The following is a description of a gene set: Cytokines mediate cell-cell communication in the immune system and represent important therapeutic targets. A myriad of studies have highlighted their central role in immune function, yet we lack a global view of the cellular responses of each immune cell type to each cytokine. To address this gap, the authors created the Immune Dictionary, a compendium of single-cell transcriptomic profiles of more than 17 immune cell types in response to each of 86 cytokines (>1,400 cytokine-cell type combinations) in mouse lymph nodes in vivo. A cytokine-centric view of the dictionary revealed that most cytokines induce highly cell-type-specific responses. For example, the inflammatory cytokine interleukin-1β induces distinct gene programmes in almost every cell type. A cell-type-centric view of the dictionary identified more than 66 cytokine-driven cellular polarization states across immune cell types, including previously uncharacterized states such as an interleukin-18-induced polyfunctional natural killer cell state. Mouse Gene Set: CUI_T_CELL_CD4_IL36A_RESPONSE_UP studied in species Mus musculus from publication Cui A, Huang T, Li S, Ma A, Pérez JL, Sander C, Keskin DB, Wu CJ, Fraenkel E, Hacohen N (PMID 38057668) Genes positively differentially expressed in cell type: CD4+ T cell upon treatment with cytokine: IL-36α in mouse lymph nodes in vivo., and this is the list of marker genes: Gbp7, Snrpd1, Psma3, Psma6, Eif2s2, Oas3, Snu13, Psmc3 (proteasome (prosome, macropain) 26S subunit, ATPase 3, NCBI Gene Id 19182), Odc1, Mrpl52, Polr1h, Tnfrsf25, Psma7, Mycbp2, Psmb5, Dad1, Ndufb9, Arpp19, Hdgf, Tmbim6, Selenow, H2-T22, Snx3, Phf5a, Uba1, Psmc5, Ifi35, Lgals3bp, Tars1, Irgm2, Relb, Bst2, Krtcap2, Nampt, Pml, Denr, D8Ertd738e, Calhm6, Skap2, Pa2g4, Snrpb, Phf11b, Eif3c, Trim34a, Ptp4a2, Idnk, Mrps34, Set, Ppa1, Phf11c, Gbp4, Cycs, Bola2, Notch1, Samsn1, Cox7b, Hnrnpa2b1, Ly6a, Usp18, Psma1 (NCBI Gene Id 26440), H2-T23, Mapkapk2, Tbrg1, Pcbp1, Mvp, Trim12a, Pou2f2, Igfbp4, Satb1, Snrpa1, Rab8b, Impdh2, Magoh, Ldha, Slfn5, Usp25, Isy1, Pdap1, Ddx24, Hsp90ab1, Yars1, Tgtp1, Nme1, Polr2f, Pdcd5, Psmb8, Elob, App, Sp110, Ddx60, Nfkb2, Cd82, Atp5f1d, Lars1, Ifit3b, Atxn2l, Erh, Ndrg3, Cd53, Gbp2, Sys1, Zbp1, Herpud1, Rtp4, Ier5, Ptma, Dhx58, Psmc4, Cct3, Psmg4, Slc3a2, Ctss, Sdf4 (NCBI Gene Id 20318), Anp32b, Uqcc2, Bud31, Anxa6, Dbnl, Cltb, Phip, Tapbp, Il2rg, Cebpb, Lgals9, Samhd1, Irf8, Rbm8a, Ly6c1, Isg20, Psma2, Sar1a, Sdhaf1, Etv6, Ssbp4 (NCBI Gene Id 76900), Jund, Stip1, Il21r, Insl6, Nmi, Sting1, Iars1, Tuba1b, Dynll2, Tcf7, Plaat3 (NCBI Gene Id 98147), Pim1, Atp5mf, Anp32e, Mitd1, Sf3b5, Mthfd2, Psmb9, Ms4a4c (membrane-spanning 4-domains, subfamily A, member 4C), Sars1, Psmb4, Eif5b, Ndufb7, Rnf213 (NCBI Gene Id 672511), Gbp8, Tgtp2, Crem, Sec61g, Psma5, H2-D1, Shmt2, Cacybp, Trim56, Bzw2, Nfkb1, Ybx1, Nop56, Larp1, Sumo2, Ly6e, Arid5b, Rcc2, Ube2l3, Gbp9, Uqcrq, Cwf19l2, Trp53, Trafd1, Parp14, Psat1, Chmp4b (charged multivesicular body protein 4B), Eif1ax, Chchd1, Aldh18a1, Hspa8, Samd9l, Slfn1 (NCBI Gene Id 20555), Chchd10, Rab10, Birc3 (baculoviral IAP repeat-containing 3), Lpp, Ranbp1, Slc7a1, Ptges3, Trib2 (NCBI Gene Id 217410), Sarnp, Ifit3, Mrpl21, Ogfr, Epsti1, Oasl2, Trim30a, Chmp2a, Ifi213, C1qbp, Ssrp1, Hsp90aa1, Cct5, Erap1, Herc6, Dnaja2, Atp5mc1, Sbno2, Gbp6, Hspa9, Cks2, Lmna, Icam1, Rbck1, Eif5a, Eif4ebp1, Serbp1, Ndufb2, Srsf2, Socs3, Cars1, Cyc1, Ifi206, Nfkbia, Ube2d3, Pcgf5, H2-Q4, Ncl, Chchd2, Hif1a, Snrpd3, Nars1, Ifi208, Lsm12, Sik3, Cyba, Snrpg, Ifitm3, Mrpl30, Prdx1, Gtpbp2, Ifi27l2a, Ddit3, B2m, Irf9 (NCBI Gene Id 16391), Eif4a1, Cox7a2, Ndufb4, Tap1, Ksr1, Psme2, Bcl3, Trim30d, Tut4, Cd274, H2-Q7, H2-K1, Cox5b, Cct8 (NCBI Gene Id 12469), Il6st, Uqcr10 (NCBI Gene Id 66152), Cox5a, Gpr65, Phb1, Xaf1, Ppp1r11, Lsm4, Irf1, Tap2, Isg15, Vasp, Hnrnpa3, Dennd5a, Sema4a, Trim12c, Irf7, Psmb10, Mrpl20, Irgm1 (NCBI Gene Id 15944), Nudc, Helz2, Strap, Ran, Naa20, Tpm3, Atp5mk, Mrpl33, H2az1, Psma4, Snhg12, Mov10, Psmd13, Igtp, Ppp1r12a, Ifit1, Psmb6, Adar, Ifih1, Tnfrsf18, Mndal, Zfp281, Atf4, Parp9, Cblb, Gadd45b, Ifi214, Vars1, Pim2, Zmiz2, Apobec3, Gbp5, Med28, Clic4, Gars1, Tnfrsf4, Rigi, Top1, Bax, Slfn8, Stat1, Phgdh, Smchd1, Psmd12, Stat3, Parp10, G3bp1, Eif3b, Stat2, Ghitm, Nlrc5, Socs1, Ifi47, Ndufc1, Eif2ak2, Tapbpl, Batf, Iigp1 (NCBI Gene Id 73042), Psme1, Casp8, Mars1, Arid5a, Ccnd2, Eif1, Dph3, Dtx3l, Edf1, Eprs1, Oas2, Ssb, Aars1, Oas1a, Psmb2, Gadd45g (growth arrest and DNA-damage-inducible 45 gamma), Hnrnpc